Given this list of marker genes Tmprss2, Stom, Ppid (NCBI Gene Id 67738), Atg5, Hacd3 (3-hydroxyacyl-CoA dehydratase 3), Cnot7, Tarbp2, Rsf1, Gbp7, Vps37b, Vps4a, P4hb, Ddb1, Cd209e, Notch1, Lgals1 (NCBI Gene Id 16852), Bsg, Smpd1, Ddx3x, Pde12, Cd74 (NCBI Gene Id 16149), Ppihl, Fkbp6, Hmgb1, Cd209c, Tmprss4, Tmem250, Srpk2, Tmem39a, Clec4g, Tbc1d20, Map3k1, Tsg101, Pkn2, Adarb1, Ppia, Trim11, Pfn1, D1Pas1, Cd209d, Kpna6, Larp1, Nr5a2, Trim38, Axl, Srpk1, Adar, Top2a, Trim30a, Tyro3, Mdfic, Dhx9, Cd4, Atg12, Kpna2, Stau1, Ppie, Vapb, Ppih, Fmr1, Rad23a, Top2b, Rab7, Furin, here is a description of the gene set: Mouse Gene Set: GOBP_POSITIVE_REGULATION_OF_VIRAL_PROCESS Any process that activates or increases the frequency, rate or extent of a multi-organism process in which a virus is a participant. species: Mus musculus